Given this list of marker genes Irak1, Nod1, Ripk2, Ube2n, Ikbkg, Ubc (ubiquitin C), Ube2v1, Tab3, Uba52rt, Tab1, Tab2, Map2k7, Ubb, Nod2, Mapk8, Traf6 (TNF receptor-associated factor 6), Rps27a, Mapk9, Mapk10, Uba52, Irak2, Map3k7, Map2k4, here is a description of the gene set: Mouse Gene Set: REACTOME_JNK_C_JUN_KINASES_PHOSPHORYLATION_AND_ACTIVATION_MEDIATED_BY_ACTIVATED_HUMAN_TAK1 studied in species Mus musculus JNK (c-Jun kinases) phosphorylation and activation mediated by activated human TAK1